The following is a description of a gene set: Genes down-regulated in granulo-monocyte progenitors versus pro-B lymphocytes. species: Homo sapiens Human Gene Set: GSE15330_GRANULOCYTE_MONOCYTE_PROGENITOR_VS_PRO_BCELL_DN Regulation of lineage potential and transcriptional priming by Ikaros. New insight is provided into a bivalent regulation of lineage priming in the HSC and its lympho-myeloid restricted progeny the LMPP by the lymphoid lineage-determining factor Ikaros Whereas Ikaros is responsible for the activation of a cascade of lymphoid expression programs and for the establishment of lymphoid potential from the HSC to the LMPP it is also responsible for the repression of stem cell and erythroid genetic programs that are incompatible with further lineage restrictions emanating from the LMPP from publication Ng SY, Yoshida T, Zhang J, Georgopoulos K (PMID 19345118), and this is the list of marker genes: TCF25, C2CD3, ZNF764, INO80, LAPTM5, RPS6KA4, SH2D2A, LAIR1, ABCD1, TRAPPC10, SHF, PHF8, TPGS2, SRI, POU2F3, RABGEF1, MINK1, TMLHE, WASHC1, FAM53C, BET1L, F2R, PXK, CNR2, LTO1, PPP2CA, UBE3B, TAPBP, MED1, MRPL24, ST6GALNAC3, RABGAP1, PI4KA, SLC23A3 (solute carrier family 23 member 3), RPS21, ZBTB2, USF1, S100A6, LRRC8C, TFEB, QPRT, SERINC3, MFSD14A, NFATC3, AGAP1, CMTM6, MRAS, PON2, XIST, GPX3, NRBF2, TTC13 (tetratricopeptide repeat domain 13), KDM4B, CPEB2, VPS37A, ZMYND8, SYPL2, BCAS3, EXOC1, EPAS1, RPL13, CRIPT, OAZ2, CACUL1, PIGO (phosphatidylinositol glycan anchor biosynthesis class O), DNAJA1, DNAJC12, NFYC, AKAP9, ABCB9, LFNG, SLC41A1, TAF13, ARHGAP17, ARHGAP5, MYL6, CDKN2B, RNF4, DAPP1, NPTX1, ETHE1, GADD45B, ATAD2B, GLTP, STX1A, GRK6, ZSCAN26, SIT1, C14orf119, WSB1, ANXA11, SLC44A1, BEX3, WBP2, STAT4, IFT172, ABO, INCA1, SDF2, CDKN1C, SLC25A51, RALGPS2, MAP2K6, FLII, HSD17B6, PBX2, NCOR1, MS4A1, CD86, CD72, SMAP2, GPR143, CRAT, SPPL3, KAZALD1, GPS2, WDR33, IER5, ANKS3, ZFYVE26, KLHL26, DDX60, STX4, ZFP1, BCL2, NCK2, DIPK2A, WNK1, KIAA0930, SYVN1, SERINC4, FAM117A, KIF5B, FBRS, HDAC11, PXMP4, OSBPL2, SMPD5, CD3E, BTG4, EMCN, PRKD3, GRIPAP1, SRFBP1, SAMHD1, LIMS2, GPANK1, TTC5, SCAND1, CNOT6, RYBP, SFXN3, MYO9B, ING2, DNASE1L1, GDF11, KRBA1, ATG16L1, SLC13A1, CRIM1, ATP6V1D, TRPC4AP (transient receptor potential cation channel subfamily C member 4 associated protein), PHIP, MDM4, ERRFI1, ACOX1, MAB21L2, S100A13, CR2, ANTKMT, MAN1A2, QRICH1, LAT, KRTCAP3, FNDC3A, PAX5, CLCN4, ARHGDIB, ABHD18, UQCRHL, ILF3, SCN3B, PIP5K1C, ZNF274, AKIRIN2, METTL23, AP3B1, MBP, ZFR2, SPO11, NUB1, RCAN3, RSRP1, GYPC, ABHD8, HMGA2, SLC22A7, NINJ1, DNAJC3, SH3GL1